Given this list of marker genes PAICS, MCM6, ZNF593, TIMM8A, EIF5A2, B3GNTL1, MRS2, MICA, PSMB3, C9orf40, STX6, RRP9, TMEM165 (NCBI Gene Id 55858), RAB27A, PRMT1, HYOU1, TRIB3, MAPKAPK3, MMACHC, LRR1, DNAJA3, SMIM7, LTBP4 (NCBI Gene Id 8425), FAM241A, MAP7D3, ALKBH2, CD109 (NCBI Gene Id 135228), DNAJC17, COA7, MITD1, GLMN, PEMT, AIFM1, GTDC1, PEPD, ELP5, RBM6, SPTSSA, GGCT, DLEU1, ATP6V1F, PUS10, FEN1, EIF2B2, CAAP1, ALG3, PUS3, TWF2, OSBPL3, RXYLT1, TPRA1, PDP2, RCC1L, HSD17B10, PTRH2, CLN6, MTHFD2, TRMT10C, RECQL4, EFNA4, C1GALT1C1, RCC1, DYM, FNTB, PGP, RAB39B, TTLL12, ERLIN1, TBCCD1, FAM98A, SH2D2A, PKNOX1, TBX21 (T-box transcription factor 21), INTS2, WDR36, HDDC3, ETFB, HPRT1, NFXL1, DUSP14, OGFOD1, RNGTT, TP53RK, LTA, PGBD2, EGR3, MLYCD, EIF3J, CLIC4, MLEC, GLS, PUM3, CIAO2A, LZIC, STIL, FH, GRK3, TMEM126B, ATP1B3, FUNDC2, MIPEP, PSMB2, PRPF38A, MRPL17, LIMK2, LCMT2, ICMT, ACOX1, COLGALT1, ZNF232, CD200, MTNAP1, PREP, ZNF780A, PRSS23, SEC11C, TCF19, ANKS1A, SLC27A2, IFRD2, MCAT, PPP1CA, MYG1, UBL5, SLC29A1, ZNF787, ORC5, BAZ1B (NCBI Gene Id 9031), DESI1, SNRNP35, GFOD1, C18orf54, AAAS, IL15RA, SLC7A1 (solute carrier family 7 member 1), PPCDC, PDHA1, METTL2B, POLD2, FAM216A, TARBP2, EIF4EBP1, HNRNPLL, POP4, IMMT, GNG8, FBXO4, SLC43A3, POLR2I, POGLUT1, MICOS13, CSNK2A1, GPN3, SNX10, ARMC6, GGH, SRM, USP45, TAF1A, NHP2, DPAGT1, BANF1, SDF2L1, EIF2B4, MRPL20, NLE1, C14orf119, SRPK1, VTI1B, FANCI, NEMP1, MCM5, PEAK1, EOMES, MCOLN2, TBL2 (transducin beta like 2), VARS2, NUP42, TRAP1, CSKMT, ETS2 (NCBI Gene Id 2114), WDR77, RBM28, PAF1, QDPR, ACSL4, CNPY3, LDHC, MRPS18A (NCBI Gene Id 64957), DHPS, UCHL3, TMEM120A, RTN4RL1, KEAP1, ATOX1, ZNF557, ISCA2, MIR3142HG, GALE, here is a description of the gene set: Human Gene Set: GSE17974_0H_VS_12H_IN_VITRO_ACT_CD4_TCELL_DN from publication Elo LL, Järvenpää H, Tuomela S, Raghav S, Ahlfors H, Laurila K, Gupta B, Lund RJ, Tahvanainen J, Hawkins RD, Oresic M, Lähdesmäki H, Rasool O, Rao KV, Aittokallio T, Lahesmaa R (PMID 20620947) The aim of this dataset was to study in detail the transcription kinetics initiated by cytokine IL-4 in early differentiation of Th2 cells. species: Homo sapiens Genes down-regulated in comparison of untreated CD4 T cells at 0 h versus the untreated cells at 12 h.